Given this list of marker genes EXOSC6, EXOSC4, MTREX, EXOSC1, EXOSC3, EXOSC5, EXOSC7, EXOSC8, MPHOSPH6, WDR74, EXOSC2, C1D, DIS3, NVL, EXOSC10, EXOSC9, here is a description of the gene set: A ribonuclease complex that has 3-prime to 5-prime processive and distributive hydrolytic exoribonuclease activity and endoribonuclease activity, producing 5-prime-phosphomonoesters. Participates in a multitude of cellular RNA processing and degradation events preventing nuclear export and/or translation of aberrant RNAs. Restricted to processing linear and circular single-stranded RNAs (ssRNA) only. RNAs with complex secondary structures may have to be unwound or pre-processed by co-factors prior to entering the complex, esp if the 3-prime end is structured. Human Gene Set: GOCC_NUCLEAR_EXOSOME_RNASE_COMPLEX species: Homo sapiens